Given this list of marker genes ZNF98, PHEX, BMPR1A, RAPGEF5, BCAP29, KCNC4, TSPY3, CDKN2B, ACADSB, KBTBD2, NCAM1, PLAAT2, SH2D7, FOXP2, KCNQ4, ZNF138 (NCBI Gene Id 7697), DHRS3, ADAMTS15, CLN8, ATP1B4, CALD1, TSPY8, DUSP26, UBE2Z, NELL2, TBC1D30, TOMM5, TSPY10, RAP2A, ZNF730, IBA57, CASKIN1, EMX2, ATP2C1, ZNF112, SYDE1, ZNF675 (zinc finger protein 675), ZBTB10, ZNF273, TCF20, HIF3A, DPYSL5, CEP350, TSPY1, TOR1AIP2, RBMS1, TSPY4, ZNF680, CNGA3 (NCBI Gene Id 44), FLRT3, PTGR3, ST18, SPSB1, EXOC5, SLC33A1, MGA, SEPHS1, SHISAL1, TRIM14, DNAJA2, CCDC57, GPR39, TSPY2, SATB2, MYO16, SKIDA1, here is a description of the gene set: Genes predicted to be targets of miRBase v22 microRNA hsa-miR-1914-5p in miRDB v6.0 with MirTarget v4 prediction scores > 80 (high confidence targets). from publication Chen Y, Wang X (PMID 31504780) studied in species Homo sapiens Human Gene Set: MIR1914_5P